Given this list of marker genes CBR3, CYP3A4, CYP4F8, CYP4F3, CYP4F11, CYP26C1, CYP4F2, CYP2W1, CYP27B1, CYP26B1, CYP26A1, CYP24A1, FGF23, CYP4F12, here is a description of the gene set: species: Homo sapiens Human Gene Set: GOBP_FAT_SOLUBLE_VITAMIN_CATABOLIC_PROCESS The chemical reactions and pathways resulting in the breakdown of any of a diverse group of vitamins that are soluble in organic solvents and relatively insoluble in water.